Given this list of marker genes EXOC3-AS1, ANKHD1, TNFSF13B, TRMT44, MBNL1, LIG1, LMCD1, MALT1, SLC1A4, NME7, TUBA3D, DECR1, NMI, RBM33, PARP9, CTRL, DHRS9, SCRN1 (NCBI Gene Id 9805), FCGR2C, CHST4, KAT2B (lysine acetyltransferase 2B), ENTPD1, GZMB, HAPSTR2, SFT2D2, SMPD3, EFEMP1, FLOT1, IDO2, HBP1 (NCBI Gene Id 26959), CWF19L1, PLEKHG1, PCGF5, CBFA2T3, SGTA, GUCY1B1, DYSF, CLEC2B, CLN8, ICAM2, PF4V1, NFE2L1, MICU1, SMIM14, SH2B2 (SH2B adaptor protein 2), KRTAP9-9, CDH13, RMI2, ASPHD2, FMO4, CCL20, NTRK2, AATBC, TRIM8 (NCBI Gene Id 81603), HLA-A, AKIRIN2, SDS, SLC6A12, DOCK8 (NCBI Gene Id 81704), LAP3, STARD4, CTSC, SAT1, PDCD1LG2, SCPEP1, MEF2A, PRXL2A, SLC38A2, ITGAD, WIPI2, ZNF385A, TRANK1, HNRNPLL, ITGBL1, CD244, CD200, CENPN, LPAR6, RUNX2, CAMK2G, POMP, NFATC3, DNAJB4, SELPLG, C1QTNF9, LINC01127, ATP6V0C, HLA-DMB (NCBI Gene Id 3109), DENND1B, CEBPG, TAGLN, EVI2B, INPP4A, C15orf32, KIR3DL1, TUBA4A, ITIH4, RAD9B, TCN2, TCF7L2, VAMP5, MAFF, OMD, PSMA5, JAK2 (NCBI Gene Id 3717), TUBA1B, STAMBPL1, IFI27, SNTB2, GBP4 (NCBI Gene Id 115361), CREB5, GHITM, APOBEC3A, GALNT3, STAC3 (SH3 and cysteine rich domain 3), GVINP1 (GTPase, very large interferon inducible pseudogene 1), ZBTB46, ANO5, BLOC1S6, AHCYL2, BLOC1S2, IPCEF1, SECTM1, TRDV2, ZNF101, IL12RB1, TACC1, PARP8, CDC42SE2, SELENOO, GBP3, ITGAL, UBR4, SFTA3, NAA11, F2RL2, ARHGEF3, PARVG, CENPH, GRK6, CLEC4E, GIMAP8, HLA-DQA1, CSF2RB, SPPL2A, CCDC141, MITF, ATP6V1A, DLAT (NCBI Gene Id 1737), ADCK1 (aarF domain containing kinase 1), EXTL2, NFKBIE, ANOS1, PLA2G12A, TMEM140, HCG27, TAP2, GSTO1, LIN7B, RGS3, LRRFIP1, RELL2, PDP1 (pyruvate dehydrogenase phosphatase catalytic subunit 1), TGFB1I1, PAK1, FCGR1BP, CCDC69, SNTG1, OASL, PLP2, UTRN, DDHD1, CAPS2, FRAT1, PRRG4, ST3GAL5, CFAP58, IFIH1, UBALD2, FAR1, DND1 (NCBI Gene Id 373863), SERTAD3, EDN1, MYO1C, TAFA2, DTX3L, ATP6V0A1, SCARF1, ARHGAP45, ZDHHC20, LY6G6E, ALAS1, ATF5, here is a description of the gene set: Genes down-regulated in comparison of macrophages cultured with M-CSF and Pam3Cyc versus macrophages cultured with M-CSF, IFNG and Pam3Cyc. Human Gene Set: GSE11864_CSF1_PAM3CYS_VS_CSF1_IFNG_PAM3CYS_IN_MAC_DN from publication Hu X, Chung AY, Wu I, Foldi J, Chen J, Ji JD, Tateya T, Kang YJ, Han J, Gessler M, Kageyama R, Ivashkiv LB (PMID 18976936) Gene expression analysis of freshly isolated CD14+ human monocytes and monocytes cultured in the presence or absence of interferon (IFN) -gamma for 24 h and then stimulated with Pam3Cys, a Toll-like receptor (TLR) 2 ligand, for 6 h. Results provide insight into mechanisms by which IFN-gamma reprograms early macrophage differentiation and subsequent response to TLR ligands. species: Homo sapiens